Given this list of marker genes TCIRG1, ZAP70, IL7R, NHEJ1, JAK1, SBDS, DCLRE1C, RMRP, STK4, SP110, PGM3, STAT1, DNAJC21, RAG1, CD8A, POMP, MCM4, POLD3, RNF31, IGHM, IL2RA, ELANE, GFI1, FCGR3A, DEF6, JAK3, RALGAPA1, PIK3CD, IKZF1, CLPB, ARHGEF1, RFX5, STAT6, ADA, EFL1, PNP, RFXAP, MAP3K14, KNSTRN, ARPC5, IL2RG, BTK, RNF168, GATA2, RFXANK, CIITA, TAP2, MALT1, RAG2, NFKB2, FLI1, SRP19, TYK2, IFIH1 (interferon induced with helicase C domain 1), ISG15, EPG5, MAGT1, DOCK8, IRF9, CTPS1, BTD, here is a description of the gene set: Recurrent viral infections species: Homo sapiens Increased susceptibility to viral infections, as manifested by recurrent episodes of viral infection. Human Gene Set: HP_RECURRENT_VIRAL_INFECTIONS